Given this list of marker genes Mlh1, Pms2, Aurkb, Lig1, Trim62, Bub1b, Vhl, Akt1, Cdkn2b, Mdm2, Trp53, B3gnt6, Brip1, here is a description of the gene set: from publication Motenko H, Neuhauser SB, O'Keefe M, Richardson JE (PMID 26092688) Mouse Gene Set: MP_INCREASED_ADENOCARCINOMA_INCIDENCE Mouse genes annotated to increased adenocarcinoma incidence (MP:0009308) retrieved from the Mouse Genome Informatics database via MouseMine species: Mus musculus